Given this list of marker genes MRPL15, LY6E, DECR1, ANKRD34A, NR2F1-AS1, ACADM, ABL2, EPS8, ILVBL, BCAR3, GEMIN6 (NCBI Gene Id 79833), GINS1, BLOC1S2, ME3, PLOD3, DHRS11, MAP4K3-DT, CRABP2, SPINT1, TMEM134, ATP5MJ, LINC01010, CTNNAL1, MIR646HG, EVL, SHOX2, COX7B, TOMM40L, ALDH1A2, EPB41L1, BCAP31, DENND4C, C17orf58, TSC22D1, KCNE1, GCLC, SPSB1, NDUFS3, TMT1B, COX5B, CSNK2B, LIPA, METTL1, NRP2, HSD3B7, TMEM70, MRPL34, KAZN, CD9, PHOX2B, LSP1, A2M, ATP5PF, CHEK2, ENHO, SLC35F3, RAB40B, GLUD1, SCARB2, POLD1, PI4K2A, TMEM91, SPP1, ASPHD1, KCNJ5-AS1, UQCRB, TMEM126B, LIMS1 (LIM zinc finger domain containing 1), ACSL6, DMAC1, COX7C, TEX264 (testis expressed 264, ER-phagy receptor), SLC50A1, GPC4, HMGA1, FHL1, EFR3A, DAG1 (dystroglycan 1), S100A1, DGLUCY, CDH6, SLC1A2, GATD3, GUSB, MYOM2, MGLL, ECI1, ARHGEF10, ZNF22-AS1 (NCBI Gene Id 442751), HMG20B, APOC1, HAVCR2, CD52 (NCBI Gene Id 1043), DCSTAMP, FAM120C, AVPI1, MITF, TSPAN32, TNFRSF11A, FABP4, LHFPL2, RAB42, DPAGT1, PPM1E, SLC29A3, APOBEC3A, CANX, LPL, NMB, RAP1GDS1, SLC17A9, ABCA6, COL8A2, TREML1, GAL, NRIP3, CD1B, PMFBP1, SPOCD1, SHB, SNAI3 (snail family transcriptional repressor 3), TIE1, MYOZ1, ASPM, SLC35B1, COL22A1, HSF2BP, SLC25A13, MCUR1, GNGT1, GRHL3, APOC2, ATP5ME, LINC00307, TMEM209, MDH1, ME1, LGALS9, TIMP3, DNPEP (NCBI Gene Id 23549), GTF2H2B, CRYZL2P, SEMA3G, ADPRS, CD84, MTUS1, DISP1, FABP5, TLE1, MRO, MRTFB, FMC1, NDUFB9, SIL1, RPS6KA2, SHANK3, CHCHD10, SCART1, NDUFA4, NRAV, FABP3, FAIM, LYSET, SLC6A12, AXL, C1orf198, TNFRSF21, CA2, GTF2IRD1, ASPH, ACOT13, KIF26B, CHD9, RAB11FIP4, GGCT, RASAL2, SNAPC5, PLCXD1, FBP1, TNNI2, MRPS25 (mitochondrial ribosomal protein S25), CAMK1, ABCB6, GEM, KCNJ1, ATP5F1A, ATP5MC3, PRELID3A, DHRS9, IQGAP2, COPRS (NCBI Gene Id 95076), IL1R2, GPAT3, DOCK3, ALDH3A2, PINLYP, ACY1 (aminoacylase 1), CLCN3, GCHFR, here is a description of the gene set: Human Gene Set: GSE36888_UNTREATED_VS_IL2_TREATED_TCELL_2H_DN Genes down-regulated in T cells: control versus IL2 stimulation for 2h. from publication Lin JX, Li P, Liu D, Jin HT, He J, Ata Ur Rasheed M, Rochman Y, Wang L, Cui K, Liu C, Kelsall BL, Ahmed R, Leonard WJ (PMID 22520852) Cytokine-activated STAT proteins dimerize and bind to high-affinity motifs, and N-terminal domain-mediated oligomerization of dimers allows tetramer formation and binding to low-affinity tandem motifs, but the functions of dimers versus tetramers are unknown. We generated Stat5a and Stat5b double knock-in (DKI) N-domain mutant mice that form dimers but not tetramers, identified cytokine-regulated genes whose expression required STAT5 tetramers, and defined consensus motifs for dimers versus tetramers. Whereas Stat5- deficient mice exhibited perinatal lethality, DKI mice were viable, indicating that STAT5 dimers were sufficient for survival. Nevertheless, STAT5 DKI mice had fewer CD4+CD25+ T cells, NK cells, and CD8+ T cells, with impaired cytokine-induced proliferation and homeostatic proliferation of CD8+ T cells. DKI CD8+ T cell proliferation following viral infection was diminished and DKI Treg cells did not efficiently control colitis. Thus, tetramerization of STAT5 is dispensable for survival but is critical for cytokine responses and normal immune function. studied in species Homo sapiens